Given this list of marker genes FGF6, FGF10, FGF9, POLR2E, POLR2G, NCBP1, FGF18, FGF5, FGF16, FGF1, POLR2C, POLR2D, POLR2K, POLR2L, POLR2F, POLR2A, POLR2B, FGF7, FGF17, FGFR2, FGF20, POLR2H, NCBP2, FGF2, FGF22, GTF2F2, POLR2J, FGF8, FGF4, FGF3, POLR2I, GTF2F1, FGF23, here is a description of the gene set: species: Homo sapiens part of: Signaling by FGFR2 in disease Reactome Pathway: FGFR2 mutant receptor activation Autosomal dominant mutations in FGFR2 are associated with the development of a range of skeletal disorders including Beare-Stevensen cutis gyrata syndrome, Pfeiffer syndrome, Jackson-Weiss syndrome, Crouzon syndrome and Apert Syndrome (reveiwed in Burke, 1998; Webster and Donoghue 1997; Cunningham, 2007). Activating point mutations have also been identified in FGFR2 in ~15% of endometrial cancers, as well as to a lesser extent in ovarian and gastric cancers. Activating mutations in FGFR2 are thought to contribute to receptor activation through diverse mechanisms, including constitutive ligand-independent dimerization, expanded range and affinity for ligand and enhanced kinase activity. FGFR2 amplifications have been identified in 10% of gastric cancers, where they are associated with poor prognosis diffuse cancers, and in ~1% of breast cancers. FGFR2 amplification often occur in conjunction with deletions of C-terminal exons, resulting in expression of a internalization- and degradation-resistant form of the receptor. Signaling through overexpressed FGFR2 shows evidence of being ligand-independent and sensitive to FGFR inhibitors. More recently, FGFR2 fusion proteins have been identified in a number of cancers; these are thought to form constitutive ligand-independent dimers based on the dimerization domains of the 3' fusion partners and contribute to cellular proliferation and tumorigenesis in a kinase-inhibitor sensitive manner.